The following is a description of a gene set: species: Mus musculus Mouse Gene Set: GOBP_NEGATIVE_REGULATION_OF_PROTEIN_POLYMERIZATION Any process that stops, prevents, or reduces the frequency, rate or extent of the process of creating protein polymers., and this is the list of marker genes: Capza1, Evl, Tmod3, Rdx, Tmod1, Vdac2, Capza2, Gsn, Cdh5, Capza3, Eml2, Eps8, Tmod4, Mtpn, Capza1b, Pecam1 (NCBI Gene Id 97748), Stmn1, Slit2, Stmn2, Lmod2, Dbnl, Kank3, Pfn1, Mkks, Dyrk1a, Sptbn1, Capn1, Tmod2, Scin, Arhgef7, Ssh2, Mapre1, Svil, Cracd, Cfl1, Add2, Myadm, Sptan1, Sgk1, Map2, Capg, Capzb, Lmod1, Tmsb4x, Myh9, Bbs4, Ssh3, Kank2, Cyrib, Tbcd, Kank1, Snca, Carmil1, Hip1r, Arpc2, Arfgef1, Tpm1, Add1, Tmsb15b2, Fkbp4, Vil1, Add3, Carmil2, Fhod3, Twf1, Kank4 (KN motif and ankyrin repeat domains 4), Pfn2, Avil (NCBI Gene Id 11567), Tubb4a (NCBI Gene Id 22153), Ssh1 (slingshot protein phosphatase 1), Twf2, Dmtn, Tmsb15l, Sptb, Lmod3, Vill, Spta1, Inpp5j, Flii, Tlr2, Prkcd, Clip3